Given this list of marker genes RP9, IER3, HOPX, SKP1, MAPKAPK3, CCR4, IRAK4 (interleukin 1 receptor associated kinase 4), HNRNPU, SNORD14E, RFC1, SKIL, THBS1, TOB1, SNX7, KLRC2, TOE1, HS3ST3A1, EIF1B, NLRP3, TGFBRAP1, EXOSC3, RMI1, EIF4G2, IL1RN, ARPP19, MRPL15, WDR75, RTN4 (reticulon 4), EEF1D, GNG11, TUBB1, PLCL1, CCL2, RNF24, PROCR, RAB27B, ALOX12, SLC25A25, SNX20, MCL1, PDE5A, RHBDF2, RPL3, LANCL1, DR1, KLRK1, IL12RB2, FERMT2, JDP2, MRPL42, ID3, MUCL1, TRPV4, EIF4E, NOP56, PPP2R5D, ARFIP1, ATF3, RRAGA, CXCL2, CFLAR, H2AC6, TCP11L1, TNFAIP6, SDHC, DCUN1D5, EPRS1, MBNL2, CEP83, TXNRD1, ABHD14A, ITGA2B, SMCR8, SAMD3, PIM2, TPRKB, PAM, RPRD1A, ADAMTS9, ANXA1, FBXO22 (F-box protein 22), CASP2 (NCBI Gene Id 835), CDADC1, WDFY1, NBEA, GADD45B, DCP2, PF4, RBM7, HIGD2A, RDH14, ERO1A, TRMT10A, CD93, KLRC1, DYNLL1, FBXO33, JAM3 (junctional adhesion molecule 3), CCT5, STRN3, PANK3, NFKBIZ, GRIA3, MRI1, TRPC6, MPIG6B, ELAC1, SOWAHC, AKAP12, SNX18, NXT1, NCBP2, NEPRO, SDC4, RNMT, FRS2, UBE2B, CCNG2, SAE1, PTBP3, ZNF670 (zinc finger protein 670), LATS2, RBPMS2, GPR180, DNAJC19, RMND5A, F5, ENC1 (ectodermal-neural cortex 1), SELP, DCAF7, PVR, PTDSS1, RRAGB, STARD3NL, CHMP1B, LONP2, GPR141, WDR76, PDE1A, PAIP2, CXCL5, CXCL1, GMCL1, UBFD1, SPTY2D1, VWF, CSNK1D, NR4A3, STRIP1, CLEC9A, ETAA1, MICU2, RARB, MIR30B, HOMER1, CACNA2D1, ZBTB33, RO60, EEF1A1, PHLDA1, SLC6A4, DLG2, MAN2B1, ADAMTS1, NOMO1, FHL1, TPD52, PRKD1, CBX7, H2AC8, here is a description of the gene set: The aim of this study was to quantify the impact of chimeric Foxp3-GFP protein on the Treg cell transcriptional program. from publication Darce J, Rudra D, Li L, Nishio J, Cipolletta D, Rudensky AY, Mathis D, Benoist C (PMID 22579475) Genes down-regulated in splenocytes from Foxp3-Fusion-GFP NOD mice: T reg (FOXP3+) versus T conv (FOXP3-) cells. studied in species Homo sapiens Human Gene Set: GSE37605_TREG_VS_TCONV_NOD_FOXP3_FUSION_GFP_DN